Given this list of marker genes UBL5 (ubiquitin like 5), SCD, CTPS1, INHBA, GPR174, IL9R, SLC10A3, GPRASP3, CNOT11, KIAA1549L, GJA4, SRSF1, PDZD11, VPS4B, SSRP1, TTLL11, KYAT3, AIMP2, MEN1, RALA, CA9, ANTKMT, TDRD7, LFNG, SLC29A1, MIB1, METTL5, DUSP1, FLOT1, FKBP5, GRIK4, POLD1, CIT, DCUN1D5, SURF1, VCPKMT, PIK3AP1, RPS6KC1, FMO2, BORCS7, LGALS7, SDHC, TMEM199, ERCC6L, RND3, VAT1L, STMP1, RRS1, HS2ST1, GALC, ITGB3BP, ATF5, UTP3, TENT4A, SCFD1, SAP30BP, NDUFV1, PNO1, NEK7, TTLL1, RUVBL1, NUP205, CDIN1, ANAPC2, ATP6V1G1, VTI1A, NDUFB5, CASP6, TMEM86A, COPS5 (COP9 signalosome subunit 5), IL7, PPIA, PGPEP1, EMC10, HOXA7, FBXO34, MVD, ACACA, RCL1, STX11, VCP (NCBI Gene Id 94731), MTMR2 (myotubularin related protein 2), YWHAH, SLC16A6, USP5, VPS53, NBEA, APOA2, KDM8, GAS2L1, ZNF800, FSTL3, STT3B, HMGN3, CISD3, AK3, PHTF2, BCAP31 (NCBI Gene Id 10134), KRT17, SOX9, TEP1, PCYT1A, RRAGC, DDX3X, NUPR1, KIF14, TRIM35, RETSAT, RAD17, TRIM46, HNRNPK, UBL4A, OPTN, GAA, NRROS (negative regulator of reactive oxygen species), TMEM241, SRXN1, SRA1, KRT18, PSMD1, MOSPD2, SRSF9, CUL2, SNRPB, RPAP2, RBM8A, NASP, ASCC1, CUL4A, PROSER2, NID2, NDUFS5, PGK2, RBIS, ST3GAL4, LONRF3, CCL24, CEP72, GMPR2, IFT74, RER1, HPGDS, BRF2, MRPS25, KCNJ8, RIOX2 (ribosomal oxygenase 2), RAP1GAP2, SPNS3, BUB3, OXSR1, GOLT1B, GINS4, MTMR9, FBXO25, COX19, SPRY2, SUMF1, POC5, PBDC1, BSPRY, SSX2IP, CCT8, CAV2 (caveolin 2), CD52, DEPP1, ERRFI1, GCNT1, HOXA5, CBX6, COL4A1, TMEM143, ZNF14, PSMB2, BAP1, MAP3K10, INTS5, PLXNA1, NSA2, PAICS, CHURC1, SAAL1 (NCBI Gene Id 113174), CHP1, NDN, TMEM231, PCNA, FADS1, METTL15 (methyltransferase 15, mitochondrial 12S rRNA N4-cytidine), PRSS22, ALDOAP2, EIF2AK1, ZC2HC1A, PSMA3, YME1L1, LRRC59, TAF11 (TATA-box binding protein associated factor 11), PLXND1, KCTD20, SYNE3, ACAT1, B9D2, here is a description of the gene set: Genes up-regulated in comparison of Th2 cells versus naive CD4 T cells. studied in species Homo sapiens Multipotential naïve CD4+ T cells differentiate into distinct lineages including T helper 1 (Th1), Th2, Th17, and inducible T regulatory (iTreg) cells. The remarkable diversity of CD4+ T cells begs the question whether the observed changes reflect terminal differentiation with heritable epigenetic modifications or plasticity in T cell responses. We generated genome-wide histone H3 lysine 4 (H3K4) and lysine 27 (H3K27) trimethylation maps in naïve, Th1, Th2, Th17, iTreg, and natural (n)Treg cells. We found that although modifications of signature cytokine genes (Ifng, Il4, and Il17) partially conform to the expectation of lineage commitment, critical transcription factors such as Tbx21 exhibit a broad spectrum of epigenetic states, consistent with our demonstration of T-bet and IFN-gamma induction in nTreg cells. Our data suggest an epigenetic mechanism underlying the specificity and plasticity of effector and regulatory T cells and also provide a framework for understanding complexity of CD4+ T helper cell differentiation. Human Gene Set: GSE14308_TH2_VS_NAIVE_CD4_TCELL_UP from publication Wei G, Wei L, Zhu J, Zang C, Hu-Li J, Yao Z, Cui K, Kanno Y, Roh TY, Watford WT, Schones DE, Peng W, Sun HW, Paul WE, O'Shea JJ, Zhao K (PMID 19144320)